The following is a description of a gene set: studied in species Homo sapiens Reactome Pathway: Neurexins and neuroligins Neurexins (NRXNs) and neuroligins (NLGNs) are best characterized synaptic cell-adhesion molecules. They are part of excitatory glutamatergic and inhibitory GABAergic synapses in mammalian brain, mediate trans-synaptic signaling, and shape neural network properties by specifying synaptic functions. As cell-adhesion molecules, NRXNs and NLGNs probably function by binding to each other and by interacting with intracellular PDZ-domain proteins, but the precise mechanisms involved and their relation to synaptic transmission remain unclear. The binding of NRXNs and NLGNs to their partners, helps to align the pre-synaptic release machinery and post-synaptic receptors. The importance of neurexins and neuroligins for synaptic function is evident from the dramatic deficits in synaptic transmission in mice lacking Nrxns or Nlgns. In humans, alterations in NRXNs or NLGNs genes are implicated in autism and other cognitive diseases, connecting synaptic cell adhesion to cognition and its disorders. part of: Protein-protein interactions at synapses, and this is the list of marker genes: HOMER1, SYT7, EPB41L1, SHANK1, DLGAP2, SYT12, LIN7A, GRM5, DLGAP1, GRIN2D, APBA3, LRRTM4, STX1A, EPB41L3, NLGN3, SYT9, DLGAP3, SYT1 (synaptotagmin 1), BEGAIN, EPB41L5, LRRTM1, LIN7B, CASK, NLGN4Y, PDLIM5, GRIN2B, SYT2, DLG3, NLGN1, DBNL, LIN7C, SHANK3, GRIN2A, SIPA1L1, SYT10, HOMER3, DLG4, LRRTM3, APBA1, NRXN2, STXBP1, SHARPIN, SHANK2, GRIN1, GRM1, DLG2, NRXN3 (NCBI Gene Id 9369), NLGN2, GRIN2C, APBA2, LRRTM2, EPB41, NRXN1, HOMER2, NLGN4X, EPB41L2, DLGAP4